Given this list of marker genes mt-Tq, mt-Co1, mt-Tr, mt-Atp6, mt-Tt, mt-Rnr2, mt-Tl1, mt-Cytb, mt-Ts2, mt-Ta, mt-Te, mt-Tp, mt-Nd4, mt-Co2, mt-Td (NCBI Gene Id 17728), mt-Nd4l, mt-Atp8, mt-Tl2, mt-Nd1, mt-Th, mt-Tw, mt-Co3, mt-Tk, mt-Ti, mt-Tc, mt-Rnr1, mt-Ts1, mt-Nd3, mt-Nd6, mt-Tn, mt-Tg, mt-Tv, mt-Nd2, mt-Tf, mt-Tm, mt-Ty, mt-Nd5, here is a description of the gene set: species: Mus musculus Mouse Gene Set: MT